Given this list of marker genes BMPR1B, RFLNA, AXIN2, CHSY1, TGFBR2, FGF18, RARG, SULF2, SHOX2, MSX2, BPNT2, HOXA11 (NCBI Gene Id 3207), ECM1, EIF2AK3, PTHLH, COL11A1, CHST11, SERPINH1, TSKU, BMPR2, GALNT3, MATN1, COMP, SOX9, SFRP2, SULF1, RFLNB, RUNX2, EXT1, SMAD7, MEX3C, SMPD3, POC1A, COL27A1, here is a description of the gene set: The process whose specific outcome is the progression of a chondrocyte over time, from its commitment to its mature state. Chondrocyte development does not include the steps involved in committing a chondroblast to a chondrocyte fate. Human Gene Set: GOBP_CHONDROCYTE_DEVELOPMENT species: Homo sapiens